The following is a description of a gene set: species: Homo sapiens Human Gene Set: HP_WOOLLY_HAIR The term wooly hair refers to an abnormal variant of hair that is fine, with tightly coiled curls, and often hypopigmented. Optical microscopy may reveal the presence of tight spirals and a clear diameter reduction as compared with normal hair. Electron microscopy may show flat, oval hair shafts with reduced transversal diameter. Woolly hair, and this is the list of marker genes: ATP7A, KRT25, KANK2, TTC5, KRT71, MPLKIP, DSP, PADI3, KRT74, DSC2, AARS1, LPAR6, LIPH (NCBI Gene Id 619396, lipase H), MAP2K1, HRAS, GAN, CCDC47, BRAF, PPP1R13L, TUFT1, DSG2, SKIC3 (SKI3 subunit of superkiller complex), PERP, SKIC2, EFNB1, JUP, TGM3, PTPN11 (protein tyrosine phosphatase non-receptor type 11)